The following is a description of a gene set: Mouse Gene Set: GOCC_NEURON_SPINE A small membranous protrusion, often ending in a bulbous head and attached to the neuron by a narrow stalk or neck. studied in species Mus musculus, and this is the list of marker genes: Grid1, Atp1a2, Lpar1, Myh10, Grin2b, Strn4, Ppp3ca, Atp2b1, Slc8a2, Ptpro, Rgs10, Gria4, Pde4b, Abi2, Arhgap32, Atp6ap2, Igf2bp1, Cdc42, Arhgap33, Sri, Mylk2, Gabra1, Kcnj2 (NCBI Gene Id 16518), Grk3, Cript, Clstn1, Epha4, Ppfia1, Abhd17b, Prrt2, Cryab, Hip1r, Cnih2, Farp1, Myo5b, Kif3b, Calb1, Cpeb4, Clcn2, Abl2, Shisa9, Cntnap2, Gabrb2, Strn, Slc1a1, Marcks, Cpt1c, Syp, Rapgef4, Baiap2, Itga8, Abr, Psmc2 (proteasome (prosome, macropain) 26S subunit, ATPase 2), Ddn, Atp2b2, Fmr1, Zfp804a, Asic2, Ppfia2, Akap5, Gsk3b, P2rx2, Nr1d1, Hspa8, Kcnd3, Itsn1, Cald1, Tiam1, Cacna1s (NCBI Gene Id 98698), Grm1, Tenm2, Dnajb1, Slc8a3, Abi3, Slc1a3, Kcna4, Arhgap44, Oprd1, Syndig1, Dip2a, Ppp1r1b, Adgrb1, Fus, Shank3, Rac1, Gria2, Abhd17a, Grin2a, Shank1, Kcnd1, Asic1, Rgs7bp, Shisa7, Mpp2, Adora1, Aplp2, Hap1, Rhoa, Chrna7, App, Als2 (alsin Rho guanine nucleotide exchange factor), Usp8, Dock10, Palmd, Dbn1, Slc9a6, Slc1a2, Bcr, Apba2, Psd, Ppp1r9a, Septin11, Sorcs2, Trpv1, Ophn1, Apbb1, Cyfip1, Grk2, Ephb2, 4930544G11Rik, Ngfr, Shank2, Grm5, Itgb1, Eef2k, Dagla, Fcgr2b, Nrgn, Comt, Gabbr1, Frmpd4, Pdlim4, Dnm3, P2rx4 (NCBI Gene Id 52272), Nos1, Hpca, Grip1, Nsmf, Asap1, Cnn3, Apba3, Drd4, Prkar2b, Mob4, Rab8a, Cfl1, Fxr1, Canx, Lzts3, Cd3e (NCBI Gene Id 12501), Apba1, Map1b, Snx1, Mtmr2, Ctnnd1, Grin1, Stx4a, Gper1, Dlg4, Pten, Slc8a1, Sipa1l1, Arrb1, Pdyn, Drd5, Gpm6a, Gria3, Dlgap2, Arrb2, Zmynd8, Actn1, Ptchd1, Nlgn1 (NCBI Gene Id 99949), Adrb2, Drd1, Zdhhc12, Neurl1a, Drd2, Shisa6 (shisa family member 6), Anks1b, Oprm1, Add1, Ntrk2, Ppp1r2, Gipc1, Abhd17c, Ptprz1, Hnrnpk, Grid2, Lrrc7, Slc9a5, Capzb, Mt3 (NCBI Gene Id 17751), Cttn, Pick1, P2rx6, Myl7, Abi3bp, Homer1, Palm, Fbxo2, Ptk2b, Kcnc3, Tanc2, Cdk5r1, Grip2, Eea1, Rph3a, Ppp1cc, Synpo, Atp1a3, Dlgap3 (NCBI Gene Id 277683), Syt11 (NCBI Gene Id 99745), Nr3c1, Lzts1, Ncoa2, Dtnbp1, Ppp1r9b (protein phosphatase 1, regulatory subunit 9B), Espn, Grm3, Rgs14, Lama2, Grid2ip, Cyp19a1, Ntsr1, Kcnd2, Dvl1, Dgki, Camk2a, Sez6 (NCBI Gene Id 20370), Ptk2, Arc, Adam10, Lrrc4, Arpc2, Pgr, Arfgef2, Srgap2, Gria1, Itpka, Ppp1ca, P2rx3, Numb, Kcnn2, Arf4, Cttnbp2, Shisa8